Given this list of marker genes Alk, Alkal1, Ltk (leukocyte tyrosine kinase), Alkal2, Ccl5, here is a description of the gene set: Binds to and increases the activity of a receptor signaling protein tyrosine kinase. studied in species Mus musculus Mouse Gene Set: GOMF_RECEPTOR_SIGNALING_PROTEIN_TYROSINE_KINASE_ACTIVATOR_ACTIVITY